The following is a description of a gene set: Appendicular hypotonia species: Homo sapiens Human Gene Set: HP_APPENDICULAR_HYPOTONIA Muscular hypotonia of one or more limbs., and this is the list of marker genes: ASCC3, CWF19L1, COG3, DHX9, SLC30A9, GEMIN5, PEX3, PUM1, TEFM, GOSR2, GBA1, POGZ, CACNA1C, FBXO28, FNIP1, UNC80, LGI3, CRELD1, SLC4A10, NRROS, PRPS1, MPV17, EXOSC9, NAPB, GNPTAB (NCBI Gene Id 79158)